Given this list of marker genes SF3B2, KIF7, RPS26, BCOR, GLI3, BMPR1B, FGFR2, RPS27, UBE2T, NUP107, RPS10, TBX5, RPL9, FANCD2, PAH, FGF10, GJA5, ESCO2 (NCBI Gene Id 5951), RPL35 (NCBI Gene Id 92393), RPS29, RPL8, RPL31, RPL35A, RPL18, GATA1, RAB23, RPL15 (NCBI Gene Id 6138), FANCA, ACTB, RPS15A, GJA8, FANCE, HEATR3, RPL5, ADA2 (NCBI Gene Id 51816), RPS20, INTU, DACT1, CANT1, RPL11, DVL1 (dishevelled segment polarity protein 1), FANCC, RPS7, RPL26, GLI1, FGFR3 (fibroblast growth factor receptor 3), SMO, RPL27, GDF5 (NCBI Gene Id 8200), ACTG1, RPS19, SALL1, CHSY1, SHMT2, RPS28, PPP2R3C, RPS17, NAA10 (NCBI Gene Id 8260), TSR2, RPS24, here is a description of the gene set: Human Gene Set: HP_DUPLICATION_OF_THUMB_PHALANX Complete or partial duplication of the phalanges of the thumb. Depending on the severity, the appearance on x-ray can vary from a notched phalanx (the duplicated bone is almost completely fused with the phalanx), a partially fused appearance of the two bones (bifid), two separate bones appearing side to side, or completely duplicated phalanges (proximal and distal phalanx of the thumb and/or 1st metacarpal). In contrast to the phalanges of the digits 2-5 (proximal, middle and distal), the proximal phalanx of the thumb is embryologically equivalent to the middle phalanges of the other digits, whereas the first metacarpal is embryologically of phalangeal origin and as such equivalent to the proximal phalanges of the other digits. species: Homo sapiens Duplication of thumb phalanx